The following is a description of a gene set: Mouse Gene Set: MIR_7019_5P studied in species Mus musculus Genes predicted to be targets of miRBase v22 microRNA mmu_miR_7019_5p in miRDB v6.0 with MirTarget v4 prediction scores > 80 (high confidence targets). from publication Chen Y, Wang X (PMID 31504780), and this is the list of marker genes: Appbp2, Kcnv2, Map1a, Inka2, Sirt2, Faxc, Gm266, Cyp2c67, Uts2r, Necap1, Ndor1 (NCBI Gene Id 78797), Trio, Smad9, Polr1d, Hs3st3b1, Tmtc2, Shisa7, Galnt6, Synpo2l, Slc30a10, Cacna2d1, Rbms3, Gabbr2, Smyd1 (SET and MYND domain containing 1), Cp, Jph3, Cdk19, Ccdc71l, Mob3b, Meox1, Copg2, Slfn8, Abraxas2, Traf6, Cfl2, Kcng2, Fndc9, Cpeb1, Lyn, Fam120c, Pipox, Foxn2, Dmbt1, Tmem170, Srrm2, Ube2f, Tomm40l, Grm5, Idh1 (isocitrate dehydrogenase 1 (NADP+), soluble), Caskin1, Mllt11, Chp1, Bak1, Dnajc30, Sh3rf3, Nfasc, Abcc2, Hspg2, Arhgef10, Nin, Dock5, Cyb5r2, Mapk8ip3, Slamf7, Gab2, Fgf9 (NCBI Gene Id 252883), Zfp592, Spock1, Prkdc, Vangl2, Prokr1, Timp3, Trim27, Magi1, Cyp2c69, Rbbp9, Optc, Bahd1, Utp18, Camk1d, Igsf23, Lmcd1, Tcte2, Entpd8, Cyp2c40, Clca3a2 (chloride channel accessory 3A2), Sulf2, Dnmt3a, Zfp872, Mef2d, Prrg3, Arrb1, Aak1, Wdr72, Atp1b4, Commd6, Cnot6, Neurog2, Gdap1l1, Sh3rf2, Cftr, Dip2b, Ggt7, Dgkb, Pts, Rtbdn, Sirpa, 4930432M17Rik, Lgalsl, Ptp4a2, Adam30, Ino80d, Gpatch8, Kctd21, Cramp1, Zfp516, Cngb3, Cxcr5, Raver2, Mtx3, Aff4, Jak3, Sh3bgr, Gcnt4, Cdh3, Spata31d1c, Sh2d1b1, Vstm4, Itpa, Prdm6, Eda (NCBI Gene Id 13607), Kpnb1, Scrn3, Vps26c, Eddm3b, Boc (NCBI Gene Id 212529), Hif3a